The following is a description of a gene set: from publication Feuerer M, Hill JA, Kretschmer K, von Boehmer H, Mathis D, Benoist C (PMID 20231436) studied in species Homo sapiens Genes down-regulated in comparison of TregLP versus TconvLP (see Table 1S in the paper for details). Human Gene Set: GSE20366_TREG_VS_NAIVE_CD4_TCELL_DN Regulatory T (Treg) cells that express the FoxP3 transcription factor are essential for lymphoid homeostasis and immune tolerance to self. Other non-immunological functions of Treg cells, such as controlling metabolic function in adipose tissue, are also emerging. Treg cells originate primarily in the thymus, but can also be elicited from conventional T cells by in vivo exposure to low-dose antigen or homeostatic expansion, or by activation in the presence of TGFβ in vitro. Treg cells are characterized by a distinct transcriptional signature controlled in part, but not solely, by FoxP3. For a better perspective on transcriptional control in Treg cells, we compared gene expression profiles of a broad panel of Treg cells from various origins or anatomical locations. Treg cells generated by different means form different sub-phenotypes identifiable by particular combinations of transcripts, none of which fully encompass the entire Treg signature. Molecules involved in Treg effector function, chemokine receptors, and the transcription factors that control them are differentially represented in these subphenotypes. Treg cells from the gut proved dissimilar to cells elicited by exposure to TGFβ, but instead they resembled a CD103+Klrg1+ subphenotype preferentially generated in response to lymphopenia., and this is the list of marker genes: RAB11FIP5, METTL9, THBS4, STEAP3, ABHD15 (NCBI Gene Id 116236), TDRP, ELMOD3, IL18R1, SHLD1, PIK3R5, VAT1L, DENND2D, FXR2, CCL7, CRYAA, IL21, LBP, SLC2A8, MSX2, EHD3, MBP, DUSP28, SFT2D2, HSD17B11, TGFBR2, CTTNBP2, ZAP70, PSMB11, CCDC167, SCUBE3, SESTD1, MSLN, FOCAD, SEMA4F, NCALD, H2BC18, UGGT1 (NCBI Gene Id 56886), KCNMB4, GRK5, SAT2, DYSF, COX10, GALNT9, CPVL, STIMATE, LITAF, TEX15, TMEM89, RNF19B, PTF1A, AXIN2, ARL2, PNMA8A, IL1RL2, GAB3, TCF7, ASB9, THADA (NCBI Gene Id 63892), OAZ3, MCOLN2, PLEKHA5, NTRK3, KLHDC7A, ATP8A2, IL4, IL17RE, RUNX3, CCDC141, IFITM10, KCNK3, LTK, SLC17A3, CNGA1, SMAP2 (NCBI Gene Id 64744), SIDT1, ST3GAL6, ATXN7L3B, SORL1, ABHD16A, NRIP3, CCDC88A, ADH1C (alcohol dehydrogenase 1C (class I), gamma polypeptide), RYR1, CD40LG, MCTP2, RALYL, PRR5L (proline rich 5 like), SLC16A5, ST6GALNAC2, HDC, SGTB, PDE5A, RASSF8, RNF19A, EVI2A, RNF43, MAN1C1, GOLM1, HPCAL1, RANBP10, RNF144A, DUSP6, FAM171B, ABCC10, SLAMF7, MMP10, CCDC70, ABLIM2, TRIM36, SGSH, CD4, TNFSF14 (NCBI Gene Id 94566), VIPR1, C11orf97, LGALS3BP, HS3ST3B1, TGFB3, PLSCR1, ENC1, ATP10A, ENPP2, CNTN1, TRPM6, TP53I13, TBX21, EVI2B, MEG3, CDK5R1, OPHN1, RHOB, RAB4A, AAK1, PPIC, GCG, FASLG, HID1, SLC9A9, INKA2, MFSD6, PARVB (NCBI Gene Id 29780), CGREF1, BATF2, EEIG1, FYB1, OLR1, PJA1, LPAR3, LACTBL1, SDR9C7, PDE7A, SMIM3, CASP1, GGT1, AMPH, IL13, EMP1, CASP4, NQO2, TSPYL4, IFNG, CDC42EP1, SNTB2, TOR3A, PDE3B, THEMIS (NCBI Gene Id 387357), TGFBR3, KANK3, TTL, PTPN11, ITGB5, ANKRD35, AR, LANCL3, TNFSF13B, C11orf65, LYPD6B, NFATC3 (nuclear factor of activated T cells 3), ANGPTL4, PIP4K2B, SAP30, RFLNB, BCHE, IL2, GMPR, DNAJC6, AP1S2, PDE6B, BCL2A1, DAPL1, C16orf96, COMMD8, RNF166, SMAP1, RMND5B, KCNK5, PAWR, PTGDR, COG1 (NCBI Gene Id 9382), SLCO3A1